Given this list of marker genes DNASE2, DFFA, NMNAT1, GPER1, FOXL2, BOK, COL6A1, TOP2A, ENDOG, DFFB, CECR2, BAX, DICER1, CIDEA, APAF1, VPS54, ACIN1, SHARPIN, EXOG, IL6, ERN2, BLCAP, DEDD2, GATA5, DNASE2B, CAPN10, HSF1, ACVR1C, CDK5RAP3, DNASE1L3, here is a description of the gene set: Human Gene Set: GOBP_CELLULAR_COMPONENT_DISASSEMBLY_INVOLVED_IN_EXECUTION_PHASE_OF_APOPTOSIS studied in species Homo sapiens The breakdown of structures such as organelles, proteins, or other macromolecular structures during apoptosis.